The following is a description of a gene set: Epithelial to mesenchymal transition (EMT) is implicated in the progression of primary tumours towards metastasis and is likely caused by a pathological activation of transcription factors regulating EMT in embryonic development. To analyse EMT-causing pathways in tumourigenesis, we identified transcriptional targets of the E-cadherin repressor ZEB1 in invasive human cancer cells. We show that ZEB1 repressed multiple key determinants of epithelial differentiation and cell-cell adhesion, including the cell polarity genes Crumbs3, HUGL2 and Pals1-associated tight junction protein. ZEB1 associated with their endogenous promoters in vivo, and strongly repressed promotor activities in reporter assays. ZEB1 downregulation in undifferentiated cancer cells by RNA interference was sufficient to upregulate expression of these cell polarity genes on the RNA and protein level, to re-establish epithelial features and to impair cell motility in vitro. In human colorectal cancer, ZEB1 expression was limited to the tumour-host interface and was accompanied by loss of intercellular adhesion and tumour cell invasion. In invasive ductal and lobular breast cancer, upregulation of ZEB1 was stringently coupled to cancer cell dedifferentiation. Our data show that ZEB1 represents a key player in pathologic EMTs associated with tumour progression. from publication Aigner K, Dampier B, Descovich L, Mikula M, Sultan A, Schreiber M, Mikulits W, Brabletz T, Strand D, Obrist P, Sommergruber W, Schweifer N, Wernitznig A, Beug H, Foisner R, Eger A (PMID 17486063) Genes up-regulated in MDA-MB-231 cells (breast cancer) after knockdown of ZEB1 by RNAi. species: Homo sapiens Human Gene Set: AIGNER_ZEB1_TARGETS, and this is the list of marker genes: PPL, MUC1, CXADR, TSPAN15, CLDN7, TACSTD2, SYTL1, OCLN, CDH4, MAL2, GJB2, MARVELD2, TSPAN1, PATJ, CD24, CDH11, TMEM30B, CDH1 (NCBI Gene Id 999), MPZL2, F11R, GJB3, DSC2, SFN, SHROOM3, CDH3, SCEL, EPPK1, CRB3, SH3YL1, PKP3, PCDH7, PMEPA1, DMKN, EPCAM, DSP